Given this list of marker genes Pdha2 (pyruvate dehydrogenase E1 alpha 2), Papolb, Zc2hc1c, Gad1, She, Ncaph, Rad17, Hspa2, Actl7b, Cdk1, Snap91, Hspa1l, Pgk2, Ybx2, Sycp1, Htr5a, Dnajb8, Tnni3, Odf1, Prkar2a, Mtnr1a, Gapdhs, Sirt1, Cftr, Chfr, Naa11, Braf, Slc12a2, Mep1b, Jam3, Camk4, Ccna1, Tuba3a, Ip6k1, Aurka, Art3, Csnk2a2, Tekt2, Stam2, Tnp1, Pgs1, Grm8, Tle4, Scg3, Clgn, Parp2, Spmap2, Lpin1 (NCBI Gene Id 50494), Ift88, Nos1, Nphp1, Pebp1, Ttk, Map7, Elovl3, Bub1, Adad1, Ddx4, Cnih2, Akap4 (A kinase anchor protein 4), Pomc (pro-opiomelanocortin-alpha), Chrm4, Alox15, Cst8, Mtor, Zpbp, Arl4a, Coil, Pias2, Nek2, Ezh2, Ccnb2, Adam2, Tulp2, H1f6, Hspa4l, Gsg1, Phkg2, Hba-x, Ddx25, Ace, Topbp1, Slc2a5, Il13ra2, Crisp2, Ldhc, Spata6, Acrbp, Dbf4, Pcsk4, Acrv1, Clvs1, Mast2, Tcp11, Dmc1, Dpep3, Rfc4, Tktl1, Hoxb1, Septin4, Zc3h14, Tssk2, Agfg1, Gstm5, Nefh, Gmcl1, Vdac3, Gpr182, Scg5, Npy5r, Cct6b, Dcc, Dmrt1, Cdkn3, Mllt10, Kif2c, Clpb, Ide, Il12rb2 (NCBI Gene Id 77231), Rpl39l, Tsn, Psmg1, Gfi1, Pacrg, Tnp2, Oaz3, Phf7, Prm2, Strbp, Nf2, Adcyap1, Taldo1, Mlf1, Pcsk1n, Znrf4, here is a description of the gene set: Mouse Gene Set: HALLMARK_SPERMATOGENESIS Mouse genes annotated to HALLMARK_SPERMATOGENESIS based on orthology mappings provided by the Alliance Genome Consortium species: Mus musculus from publication Howe DG, Blake JA, Bradford YM, Bult CJ, Calvi BR, Engel SR, Kadin JA, Kaufman TC, Kishore R, Laulederkind SJF, Lewis SE, Moxon SAT, Richardson JE, Smith C (PMID 30224793)